The following is a description of a gene set: from publication La Manno G, Gyllborg D, Codeluppi S, Nishimura K, Salto C, Zeisel A, Borm LE, Stott SRW, Toledo EM, Villaescusa JC, Lönnerberg P, Ryge J, Barker RA, Arenas E, Linnarsson S (PMID 27716510) Cell types are named using anatomical and functional mnemonics prefixed by 'm' or'h' to indicate mouse and human respectively: OMTN, oculomotor and trochlear nucleus; Sert, serotonergic; NbM, medial neuroblast; NbDA, neuroblast dopaminergic; DA0-2, dopaminergic neurons; RN, red nucleus; Gaba1-2, GABAergic neurons; mNbL1-2, lateral neuroblasts; NbML1-5, mediolateral neuroblasts; NProg, neuronal progenitor; Prog, progenitor medial floorplate (FPM), lateral floorplate (FPL), midline (M), basal plate (BP); Rgl1-3, radial glia-like cells; Mgl, microglia; Endo, endothelial cells; Peric, pericytes; Epend, ependymal; OPC, oligodendrocyte precursor cells. Human Gene Set: MANNO_MIDBRAIN_NEUROTYPES_HPROGBP studied in species Homo sapiens, and this is the list of marker genes: MXRA8, TET1, CROT, KNL1 (NCBI Gene Id 57082), CRYM, NEMP2 (nuclear envelope integral membrane protein 2), GINS1, ZFP36L1, TP53TG1, WEE1, GTSE1, FZD2, ZNF738, PRR11 (NCBI Gene Id 55771), CCND1, CDCA5, DMRTA2, FGFR3, MSI1, FAM72A, RFX4, HMGA1, KIRREL2 (NCBI Gene Id 84063), CENPF, HMGN2, RAD51AP1, CTNNAL1, H4C12, SHISA2, LRP2, HELLS, PLIN3, GNG5, AURKA, KIF23, MDK, NOTCH1, PMAIP1, DMBX1, TIMELESS, TMEM97, STON1-GTF2A1L, MCM6, RTKN2, KIF15, PARPBP, TSIX, GBX2 (NCBI Gene Id 2637), PAICS, WNT7A, PRC1, SMC4, TK1, IRX3 (NCBI Gene Id 79191), IGF2BP1, XRCC3, MID1, SAPCD2, CDC25C, CENPW, RPL18, SP5, ANTXR1, DIS3L2, H2AZ1, HMGB2, GULP1, H2BC9, MTTP, CDK1, DSN1, LIMCH1, PIMREG, CDHR1, PAPPA, RPS19, CNPY1, SFRP2, PDPN, SHISA3, MIS18BP1, RPL23A, CHEK1, CCNA2, FZD1 (frizzled class receptor 1), SCUBE1, HMMR, KIF22, EEF1D, SKA3, PCDH8, SOX9, WNT5A, PIEZO2, PTX3, CLSPN, TDP1, SPAG5 (sperm associated antigen 5), SALL4, BOC, CCNB2, MCM7, LAMA1, NPTX2, TRIM59, FOXA2, IGDCC3, ASCL1, LRRN1, NES, ARL4A, LMNB2, BRCA2, H3C2, H2AX, NAXE, HES5, TPX2, MKI67, UBE2T, SNRPF, CENPQ, LHFPL6, STK17B, ASPM, GSTP1, PLSCR1 (NCBI Gene Id 5359), ASB2 (ankyrin repeat and SOCS box containing 2), FBLN2, CENPK, FAM83D, COL2A1, RNF13 (ring finger protein 13), CDCA8, NCAPG2, C21orf58, CKS2, SRF, PLK1, CPSF3, TYMS, POU3F2, GINS2, LBR, GPSM2, DEPDC1, PLP1 (NCBI Gene Id 5354), HJURP, BIRC5, CDCA3, GMNN, HMGA2, ZNF519, TMPO, AURKB, OTX2, CELSR2, ARHGEF26, MELK, ESCO2, LGR5, KCNQ2, HAT1, ACTL6A, ATAD2, H4C9 (NCBI Gene Id 8294), BUB1, IRX2, BCAT1, PCNA, HK2, NELL2 (NCBI Gene Id 4753), ENOSF1, TTK, DEPDC1B, DLGAP5, CCN1, RPL13AP5, LMNB1, IGFBP2, SOX2, NCAPG, FNDC3B, RFTN2, AJUBA, SHROOM3, CKAP2, CENPU, H3C3, PDZRN3, FAT3 (NCBI Gene Id 440062), BDH2, PTTG1, KIF18A, CKAP2L, YAP1, CEMIP2, RIDA, MND1, MAD2L1, RCOR2, CCN2, TOP2A, PIF1, FANCB, RNASEH2A, TROAP, ZNF395, RFC4, TGIF2, SPC25, KIF2A, RACGAP1, LITAF, C19orf48P, TACC3, ZC3H12C, POU3F1, ZGRF1, PRTG, STON1, SGO2, ZWINT, CCDC34, MCM5, CDKN3, HES1, BRCA1, RFC3, DSG2, CKS1B, TMSB15A, MIR221, DHFR, CRB2, SPDL1, ILDR2, SGO1 (shugoshin 1), MYLK, RPS14, VIT, CDK2, FBXO5, KIF2C, VEPH1, SOX1, DSC2, PHGDH, NRARP, SFRP1, ECT2, SLC39A4, CENPE, BUB1B, RRM2, DNAJC9, ANLN, PBK, UBE2C, NCAPH, MIR454 (NCBI Gene Id 768216), EPHB2, DBF4, RPA3, FAT2, NUSAP1, CIP2A, NUF2, ITGB8, VIM, CENPN, DTX4, AAMDC, MYBL2, SLC6A8, SYT2, NEK2, ZFP36L2, ITGB3BP, FANCI, ARHGAP11A, PDE1A, HERC2P4, NCAPD2, ANP32E, KIF11, KIF4A, FOXM1, OTX2-AS1, CRYZ (NCBI Gene Id 1429), KIF2B, CCNB1, MIR99AHG, UHRF1, JAM2, MAT2B, KNSTRN, KIF14, ZNF878, SALL1